Given this list of marker genes CFTR, C8B, SLC6A14, GCLC, EDNRA, C5, CYBA, TGFB1, STX1A, CEACAM3, CYBB, HFE, RPGR, C6, IL2RG, DCTN4, CFB, C7, SLC11A1, HMOX1, GSTM3, SCNN1G, CFI, SCNN1B, MBL2, NCF1, SCNN1A, SERPINA1, ITGB2, CLCA4, SLC26A9, MIF, KCNN4, CEACAM6, NCF2, IL12RB1, SLC9A3, here is a description of the gene set: Human Gene Set: HP_RECURRENT_GRAM_NEGATIVE_BACTERIAL_INFECTIONS studied in species Homo sapiens Recurrent gram-negative bacterial infections Increased susceptibility to infection by gram-negative bacteria, as manifested by a medical history of repeated or frequent infections by these agents.